Given this list of marker genes IRS2, ZFP36L2, MAFF, IL27RA, ZNF747, AMOTL2, EPHB4, NAB2, SAT1, HNRNPH1, GEM, IER5, GDF15, NAP1L1 (NCBI Gene Id 64165), MAP3K14, TAGLN, CHST3, UBXN4, TBL3, OGFR, MCF2L, CXCL8, DUSP4, TCIM, DAXX, NDEL1, MAP2K3, TNFRSF10B, F3, LAT2, BCL10, DUSP6, HBEGF, MVD, SOWAHC, CYTH1, TGFA (transforming growth factor alpha), CDC27, CDKN1A, CLCF1, AREG, JUP, ZPR1, VPS37B, CXCL1, MCL1, EPHA2, JAG1, KDM6B, DAG1, CEP104 (NCBI Gene Id 9731), ARRB1, PUS3, MTARC2, MATK, BIRC2, CDC42EP2, ARPC4, JUND, CXCL2, SNAI1, GADD45A, CYP1B1, FOXC2, FOSL1, BDNF, RUNX3, PLAUR, here is a description of the gene set: Human Gene Set: AMIT_EGF_RESPONSE_120_HELA species: Homo sapiens Genes whose expression peaked at 120 min after stimulation of HeLa cells with EGF. from publication Amit I, Citri A, Shay T, Lu Y, Katz M, Zhang F, Tarcic G, Siwak D, Lahad J, Jacob-Hirsch J, Amariglio N, Vaisman N, Segal E, Rechavi G, Alon U, Mills GB, Domany E, Yarden Y (PMID 17322878) Signaling pathways invoke interplays between forward signaling and feedback to drive robust cellular response. In this study, we address the dynamics of growth factor signaling through profiling of protein phosphorylation and gene expression, demonstrating the presence of a kinetically defined cluster of delayed early genes that function to attenuate the early events of growth factor signaling. Using epidermal growth factor receptor signaling as the major model system and concentrating on regulation of transcription and mRNA stability, we demonstrate that a number of genes within the delayed early gene cluster function as feedback regulators of immediate early genes. Consistent with their role in negative regulation of cell signaling, genes within this cluster are downregulated in diverse tumor types, in correlation with clinical outcome. More generally, our study proposes a mechanistic description of the cellular response to growth factors by defining architectural motifs that underlie the function of signaling networks.